Given this list of marker genes SLC26A3, GJA1, SLC26A11, SLC22A1, SLC25A10, SLC6A11, SLC1A2, SLC25A19, ABCG2, SLC27A1 (solute carrier family 27 member 1), SLC33A1, SLC26A1, SLC25A13, SLC26A10P (solute carrier family 26 member 10, pseudogene), SLC26A6, SLC25A39, SLC22A2, ABCC10, SLC25A47, SLC7A9, SLC25A42, SLC16A6, SLC44A4, SLC19A3, ABCC4, SLC13A4 (solute carrier family 13 member 4), SLC6A6, SLC26A7, SLC35B3, ABCC2, RALBP1, SLC1A1, SLC25A17 (NCBI Gene Id 10478), SLC13A3, MFSD12, SLC13A1, SLC47A1, SLC7A11, ABCD1, ABCC1, ABCD2, SLC25A26, UCP2, ABCC5, SLC26A5, CTNS, SLC3A1, SLC19A2, SLC25A40, SLC6A13, SLC26A8 (solute carrier family 26 member 8), SLC26A4, SLC25A16, SLC26A2, SLC43A2, SLC1A4, SLC36A1, SLC26A9 (solute carrier family 26 member 9), ABCC6, SLC25A12, ABCC11, SLC5A6 (NCBI Gene Id 8884), SLC35B2, ABCC3, here is a description of the gene set: species: Homo sapiens Enables the transfer of a sulfur compound from one side of a membrane to the other. Human Gene Set: GOMF_SULFUR_COMPOUND_TRANSMEMBRANE_TRANSPORTER_ACTIVITY